Given this list of marker genes HCG4 (HLA complex group 4), CDH18, SLC13A1, IFT81, TRIM54, MS4A10 (NCBI Gene Id 64235), TBC1D24, CCBE1, FAM178B, BEX4, TMEM89, BHLHA9, OTC, LCE3B, FLYWCH2, PLA2G5, FAM149A, REP15 (RAB15 effector protein), CCDC191 (NCBI Gene Id 57577), P2RY13 (purinergic receptor P2Y13), C4BPB, SLC25A34, ANO8, OAZ2, POU6F2, GJA8, SLC5A11, DNTT, ALLC, SPOCK2, DLGAP2, PPFIBP2, SYCP1, CELF3, IHH, EGR2, ST3GAL5, GJA4, PRKACA, EVC2, C19orf33, GJB2, FAM170A, ADAMTS7, TRH, PALLD, ARFIP1, TOX2, KCNJ2, SHISA9, SFN (NCBI Gene Id 2810), CHST3, IL20RA, ATP6AP2, GP6, NUDT12, OLIG1, PABPN1L, SCN3B, MAN1C1, CGN, CD74, LRRN3, SLC1A4, HPN, ATP1B1, SYN1, ASB2, BRD8, CYP1B1, CLDN3, KATNAL1, PLXNA2, MMD2, BCO1, GNA14 (NCBI Gene Id 9630), DNA2, GRIP1, MAPK12, RYR1, FAM83G (NCBI Gene Id 650803), COMT, PYY, RTN4RL2, PXT1, TTC3, ARHGAP31 (NCBI Gene Id 57514), RIBC2, RASIP1, KRT31, LTBP4, DVL3, CDHR5, SYNDIG1, DYDC2, SLC16A8, CHRM1, EMX1 (empty spiracles homeobox 1), COLEC10, POU3F2, PAMR1, HMGN3, CHRNG, LIMA1, PID1, APOA4, BMX, DUSP18, SLC22A25, CDK5R1, FGD4, CD81, FOXC1, GFRA3, ST8SIA6, HACD3, ALOX5AP, SERPINE1, CHST6, BANF2, ANGPT1, S100A9, CALY, INSRR, TET1, STAT1, SRXN1, CFI, HUNK, MAPK11 (NCBI Gene Id 5600), NDRG1, SNTA1, FAM83F, PFKM, PLEKHH3, TTC22, FIGLA, SPARCL1, CHAT, IL36G, EBI3, ARHGAP33 (NCBI Gene Id 93092), SLC52A2, LAMA5, FAM168A, SSC5D (NCBI Gene Id 284297), SP6, MC3R, BTNL9, SHANK3, GAD2, ADAM15, REG3G, KRT32 (NCBI Gene Id 3882), CCDC57, C4orf54, STPG3, MYO15B, CCDC25, SLC9B2, PRDM14, TNFRSF17, TRPM6, TMEM35A, WNT10A, CXCR5, PECAM1, GREM2, TNFSF13B, SRGAP3, SPESP1, DRAXIN, GPR35, PLCD1, DIRAS1, PLXNB1, CD99, SH2D5, XRCC3, IGSF21, ADTRP, CDX2, CHRNB2, A1CF, PARD3, GJA10, RAC3, DLG3, TREM2, ATP1A3, OSR1, BMP1, GRIK4, LINGO3, SCN8A, GPR135, NPR3, AS3MT, FAM3C, HOXB9 (NCBI Gene Id 3219), here is a description of the gene set: studied in species Homo sapiens Human Gene Set: GSE36078_UNTREATED_VS_AD5_INF_MOUSE_LUNG_DC_UP Discrimination between self vs. non-self and adequate response to infection and tissue damage are fundamental functions of the immune system. The rapid and global spread of known and emerging viruses is a testament that the timely detection of viral pathogens that reproduce within host cells, presents a formidable challenge to the immune system. To gain access to a proper reproductive niche, many pathogens travel via the host vasculature and therefore become exposed to humoral factors of the innate immune system. Although a cascade of coagulation factors plays a fundamental role in host defense for “living fossils” such as horseshoe crabs (Xiphosurida spp), the role of the coagulation system in activation of innate responses to pathogens in higher organisms remains unclear. When human type C adenovirus (HAdv) enters the circulation, 240 copies of coagulation factor X (FX) bind to the virus particle with picomolar affinity. Here, using molecular dynamics flexible fitting (MDFF) and high resolution cryo-electron microscopy (cryo-EM), we defined the interface between the HAdv5 hexon protein and FX at pseudo-atomic level. Based on this structural data, we introduced a single amino acid substitution, T424A, in the hexon that completely abrogated FX interaction with the virus. In vivo genome-wide transcriptional profiling revealed that FX-binding-ablated virus failed to activate a distinct network of the early response genes, whose expression depends on transcription factor NFKB1. Deconvolution of the signaling network responsible for early gene activation showed that the FX-HAdv complex triggers MyD88/TRIF/TRAF6 signaling upon activation of toll-like receptor 4 (TLR4) that serves as a principal sensor of FX-virus complex in vivo. Our study implicates host factor “decoration” of the virus as a mechanism to trigger innate immune sensor that respond to a misplacement of coagulation FX from the blood into intracellular macrophage compartments upon virus entry into the cell. Our results further the mounting evidence of evolutionary conservation between the coagulation system and innate immunity. from publication Doronin K, Flatt JW, Di Paolo NC, Khare R, Kalyuzhniy O, Acchione M, Sumida JP, Ohto U, Shimizu T, Akashi-Takamura S, Miyake K, MacDonald JW, Bammler TK, Beyer RP, Farin FM, Stewart PL, Shayakhmetov DM (PMID 23019612) Genes up-regulated in CD11c+ monocytes: control versus HAdv5 infection.